Given this list of marker genes Fgf5, Fgf4, Fgf23, Fgf8, Fgf16, Fgf17, Hras, Fgf1, Fgf2, Shc1, Fgf20, Grb2, here is a description of the gene set: electronically inferred by orthology from the curated human pathway This event has been computationally inferred from an event that has been demonstrated in another species.<p>The inference is based on the homology mapping from PANTHER. Briefly, reactions for which all involved PhysicalEntities (in input, output and catalyst) have a mapped orthologue/paralogue (for complexes at least 75% of components must have a mapping) are inferred to the other species. Reactome Pathway: SHC-mediated cascade:FGFR3 species: Mus musculus part of: Downstream signaling of activated FGFR3